Given this list of marker genes PIAS1, SEH1L, MDM2, NDC1, SUMO1, POM121, VHL, NUP160, PML, NUP62, NUP50, UBE2I, NUP210, TRIM27, NUP37, RANBP2, SEC13, PIAS2, NUP107, AAAS, NUP98, NUP155, NUP93, RAE1, NUP214, NUP54, NUP88, NUP153, NUP205, TPR (translocated promoter region, nuclear basket protein), PIAS4, POM121C, NUP43, NUP85, NUP35, NUP188, NUP58 (NCBI Gene Id 9818), NUP42, NUP133, here is a description of the gene set: part of: SUMO E3 ligases SUMOylate target proteins Reactome Pathway: SUMOylation of ubiquitinylation proteins studied in species Homo sapiens Several ubiquitin E3 ligases are regulated by SUMOylation. SUMOylation appears to be necessary for nuclear import of MDM2, the E3 ligase that ubiquitinylates TP53 (p53). SUMOylation of VHL abolishes its ubiquitin ligase activity. HERC2, RNF168, and BRCA1 are ubiquitin ligases that are SUMOylated during DNA damage response and repair.